The following is a description of a gene set: studied in species Homo sapiens Human Gene Set: GOBP_NEGATIVE_REGULATION_OF_RNA_SPLICING Any process that stops, prevents, or reduces the frequency, rate or extent of RNA splicing., and this is the list of marker genes: NPM1 (NCBI Gene Id 4869), RPS26, SRSF10, SRSF4, RNPS1, PCBP4, CELF4, SRSF9, SRSF6, RBM42, SFSWAP, U2AF2, RBMX, PTBP2, TMBIM6, C1QBP, SRSF7, RBM20, ACIN1, DYRK1A, HNRNPK, RBM10, SAP18, PTBP1, RPS13, SRSF12, PTBP3